Given this list of marker genes ALDH9A1, SHMT1, BBOX1, TMLHE, here is a description of the gene set: Carnitine is required for the shuttling of fatty acids into the mitochondrial matrix and its deficiency is associated with metabolic diseases. It is abundant in a typical Western diet but can also be synthesized in four steps from trimethyllysine (generated in turn by the S-adenosyl-methionine-mediated methylation of lysine residues in proteins, followed by protein hydrolysis). The enzymes that catalyze the first three steps of carnitine synthesis, converting trimethyllysine to gamma-butyrobetaine, are widely distributed in human tissues. The enzyme that catalyzes the last reaction, converting gamma-butyrobetaine to carnitine, is found only in liver and kidney cells, and at very low levels in brain tissues. Other tissues that require carnitine, such as muscle, are dependent on transport systems that mediate its export from the liver and uptake by other tissues. part of: Metabolism of amino acids and derivatives Reactome Pathway: Carnitine synthesis studied in species Homo sapiens